Given this list of marker genes SCNN1A, CALHM1, SCNN1D, SCNN1B, SCNN1G, CALHM3, here is a description of the gene set: part of: Sensory perception of taste Reactome Pathway: Sensory perception of salty taste studied in species Homo sapiens Initially, type I taste bud cells were suggested to be responsible for tasting low concentrations of salt, however a subset of type II taste bud cells are now thought to be responsible. The identity of salt-tasting cells remains a subject of current research. The ability to taste low concentrations of salt is at least partially due to an amiloride-sensitive sodium channel believed to be an SCNN channel (ENaC channel). SCNN complexes contain the pore-forming subunit SCNN1A or SCNN1D, and the modulatory subunits SCNN1B and SCNN1G, all of which have been detected in human taste buds. Knockout of SCNN1A in mice abolished amiloride-sensitive salt taste and attraction to low concentrations of salt, however SCNN1B and SCNN1G do not colocalize with SCNN1A in taste cells of mice, raising the question of the subunit composition of the SCNN complex. SCNN1D is present in human taste cells but not in mouse taste cells.<br>In humans, a SCNN channel containing SCNN1A or SCNN1D located in the plasma membrane is believed to transport sodium ions from the extracellular region into the cytosol, resulting in depolarization that causes CALHM1:CALHM3 channels to open and release ATP, a neurotransmitter, from the cytosol to the extracellular region.